The following is a description of a gene set: The stimulation of the activity of NF-kappaB-inducing kinase through phosphorylation at specific residues. species: Homo sapiens Human Gene Set: GOBP_ACTIVATION_OF_NF_KAPPAB_INDUCING_KINASE_ACTIVITY, and this is the list of marker genes: COPS8, ZFP91, TLR6, TNFSF15, CARD14, TNFRSF10B, CARD10 (NCBI Gene Id 29775), CHI3L1, TLR3, TNFRSF10A